The following is a description of a gene set: Any process that modulates the frequency, rate or extent of mRNA processing, those processes involved in the conversion of a primary mRNA transcript into a mature mRNA prior to its translation into polypeptide. studied in species Homo sapiens Human Gene Set: GOBP_REGULATION_OF_MRNA_PROCESSING, and this is the list of marker genes: RBM25, NCBP2, RBM3, ARGLU1, HNRNPA1, SRSF12 (NCBI Gene Id 135295), SRSF7, DAZAP1, ZFP36L1, CIRBP, CDK11B, HNRNPK, PRPF19, CCNB1, WDR77, RNPS1, CDK11A, CELF3, TRA2A, NOVA1, PUF60, SFSWAP, KHDRBS1, RBMY1A1, PRDX6, SON, RBMY1F (NCBI Gene Id 159163), KAT8, C1QBP, PCBP4, CELF6, HNRNPL, NCL, RBM8A, RBM24, SNW1, HMX2, RBPMS, QKI, RBPMS2, CDK9, NUP98, NSRP1, RBM4, CLNS1A, STH, KHDRBS3, SMU1, RBMY1E, ZBTB7A, NCBP1, PTBP1, TRA2B, SRSF4 (serine and arginine rich splicing factor 4), MAGOH, THUMPD2 (NCBI Gene Id 80745), CDC73, UPF3B, REST, UPF3A, DHX36, SRSF10, CELF1, SAFB, RBM10 (RNA binding motif protein 10), EXOSC10, JMJD6 (NCBI Gene Id 23210), SRSF6, NOVA2, U2AF2, FMR1, LARP7, IWS1, PRMT5, RBM15B, ALKBH5, CELF4, SRSF3, RBMY1J, SRPK1, WTAP (NCBI Gene Id 9589), DHX9, CELF2, RBM7, RBMY1D, CWC22, UPF1, BARD1, ACIN1, MAGOHB, SRRM4, SRSF8, RBFOX3, SRRM1, METTL16, ARB2A, SLC39A5, RBM47, SRPK2, TIA1, HNRNPU, RBM23, CELF5, MYOD1, KHDRBS2, SAP18, RBM20, RBM11 (NCBI Gene Id 54033), RBM42, PTCD2, SNRNP70, RBM39 (NCBI Gene Id 9584), HDAC7, RBMXL1, THRAP3, DYRK1A, RBFOX2, SAFB2, AHCYL1, CPEB1, RBM15, SRSF9, DDX17, RBFOX1, DDX5, RBMX, SRSF2, SF1, YTHDC1, NPM1, SRPK3, RBM5, RBMY1B, SLTM